The following is a description of a gene set: The side (leaflet) of the plasma membrane that faces the lumen. Mouse Gene Set: GOCC_LUMENAL_SIDE_OF_ENDOPLASMIC_RETICULUM_MEMBRANE studied in species Mus musculus, and this is the list of marker genes: Canx, Sppl2a, H13, H2-Q10, Sppl3, H2-K1 (histocompatibility 2, K1, K region), H2-T3, H2-Q7, Sppl2b, H2-T23, Pkd2, H2-D1, Sppl2c